The following is a description of a gene set: Pathway Definition from KEGG: Vpr == (DCAF1+DDB1+CUL4) -> ATR -> CHEK1 -| CDC25C -> (CCNB+CDK1) HIV Vpr to CDC25-cell cycle G2M. Pathway ID: N00456. Pathway type: Pathogen. Pathway class: nt06161 Human immunodeficiency virus 1 (HIV-1). Human Gene Set: KEGG_MEDICUS_PATHOGEN_HIV_VPR_TO_CDC25_CELL_CYCLE_G2M species: Homo sapiens, and this is the list of marker genes: CCNB2, DCAF1, CDC25C (cell division cycle 25C), ATR, CUL4A, CCNB3, DDB1, CHEK1, CUL4B, CCNB1, CDK1